Given this list of marker genes ARHGAP15, GPR27, LIPA, COQ4, PLXDC2, PTPRC, DUSP3, GALK2, PRTFDC1, CYYR1, MAFF, ANO7L1, ABCB1, PDZD2, PYGL, TESPA1, TBX15, CNKSR1, LMNA, RSL1D1, GSTO2, SPINT2, ZNF521, BNIP3, EMP1, PROM1, TBXAS1, HOXA3, HOOK1, PIP5K1B, ROBO3, NPR3, SNTB1, ROBO4, EIF3J-DT (EIF3J divergent transcript), DUSP18, URI1, RAB37, TAFA2, ZBTB46, FOCAD, MAST4, SLC5A8, PLOD2, S100A6, SIRT4, ARHGEF40, DEPTOR, RPL10A, ADAMTSL4 (ADAMTS like 4), PNP, IFI30, TAL1, NYNRIN, SEL1L2, PRKAG2-AS1, EFNB2, SERPINB6, MKKS, CZIB, RNF150, MRPS18C, FGFR2, STOM, ELOVL7, SIK1, TNRC18, MTG2, RBFOX2 (RNA binding fox-1 homolog 2), IL6R, SAMSN1 (SAM domain, SH3 domain and nuclear localization signals 1), TPP1, NOTCH4 (NCBI Gene Id 4855), DYNLT5, FKBP11, PLSCR4, SLC35D2, BEX3, STK36, SMIM10L1, GATAD1 (NCBI Gene Id 79636), FADD, SELENOW, GUCY1B1, LOXL3, TMEM42 (NCBI Gene Id 131616), IQGAP2, CSRP1, FRY, HMGA2, CTDSPL, MIR23AHG, ITGA9, CLDN10, CTSW, S100A4, BIRC3, FTL, SLC22A15, CLNS1A, BRSK2, BEND4, B3GAT3, TLE3, SERPINH1, APLP2, CANX, ADAM28, CD4, EEF2, BACE2, ADGRG6, DHRS7, PRORSD1P, ARHGAP22, HEXB, IDS, HSD17B8, KIT, THEM4, CYTL1, TFPI, C11orf21, MLLT3, WAPL, SPIRE1, MX2, LINC00667, LAPTM4B, ST13, ERO1A, STING1, MMRN1, GATA2-AS1, EEF1B2 (eukaryotic translation elongation factor 1 beta 2), ALDH1A1, BAIAP2-DT, PLEKHA2, MYO1F, JAM2, CD164, SPIN3, PTPN7, CORO1B, PAAF1, MAP7, CHMP2A, IFTAP, ALCAM, TBC1D9B, BLVRB, B4GALT5, SKAP1, ADAM8, CLIC1, EXOSC7, PAQR7, TRIP10, ATP5F1D, FKBP9, KLHDC8B, MRPL36 (mitochondrial ribosomal protein L36), MAPRE3 (microtubule associated protein RP/EB family member 3), LOXL1, MPIG6B, HSP90AB1, RAB27B, RPL36AL, RAB3D, FGD5, STON2, HSD17B12, ICAM3, ACACB, IMPA2 (inositol monophosphatase 2), CALN1, SDSL, WDR35, CALCRL, SPATA6, PRMT2 (NCBI Gene Id 3275), FCSK, ANGPT1, SS18L2, CRHBP, LRRFIP2, SRGN, CAVIN1, GPI, NR4A2, LYN, HCG4, C1RL, GALNT6, MYCT1, RPS10P5, RBPMS, here is a description of the gene set: Human Gene Set: GSE9509_LPS_VS_LPS_AND_IL10_STIM_IL10_KO_MACROPHAGE_30MIN_UP IL-10 regulates anti-inflammatory signaling via the activation of STAT3, which in turn controls the induction of a gene expression program whose products execute inhibitory effects on pro-inflammatory mediator production. Here we show that IL-10 induces the expression of an ETS family transcriptional repressor, ETV3 and a helicase family co-repressor, SBNO2 (Strawberry notch homolog 2) in mouse and human macrophages. IL-10-mediated induction of ETV3 and SBNO2 expression was dependent upon both STAT3, and co-stimulus through the TLR pathway. We also observed that ETV3 expression was strongly induced by the STAT3 pathway induced by IL-10 but not STAT3 signaling activated by IL-6, which cannot activate the anti-inflammatory signaling pathway. ETV3 and SBNO2 specifically repressed NF-kB-mediated transcription and can physically interact. Collectively our data suggest that ETV3 and SBNO2 are components of the pathways that contribute to the downstream anti-inflammatory effects of IL-10. We compared expression profiles of macrophages isolated from IL-10 -/- mice. Macrophages were treated with either LPS or LPS plus IL-10. Treatment times were 10, 20 and 30 minutes. species: Homo sapiens Genes up-regulated in macrophages with IL10 knockout in response to 30 min treatment by: LPS versus LPS and IL10. from publication El Kasmi KC, Smith AM, Williams L, Neale G, Panopoulos AD, Watowich SS, Häcker H, Foxwell BM, Murray PJ (PMID 18025162)